Given this list of marker genes Tubgcp5, Szt2, Hps4, Tnrc18 (NCBI Gene Id 381742), Snord42b, Stag1, Nes, Ppih (peptidyl prolyl isomerase H), Hyi, Fbxw4, Zfp592, Rab30, Coq4, Cfap298, Sox1, Peli1, Nf1, Acaa2, Wdr77, Mogs, Krr1, Gm20257, Cops7a, Bloc1s4, Zbtb45, Nckap5, Ift80, Mix23, Pdgfa (platelet derived growth factor, alpha), Tut4, Abcc4, Dgkd, Zbtb7c, Ogfod2, Msmo1, Mir2861 (NCBI Gene Id 100499514), Opcml (NCBI Gene Id 73045), Helq, Phospho1, Psmb1, Sqstm1, Lrrc8b, Zeb1, Gm13427, Gm15927, Spred1, Dhrs1, Cox18, Mapk1, Fscn1, Mapk6, Thoc5, Plekhm3, Gt(ROSA)26Sor, Faim, Brcc3, Mtf1, Tomm5, Nr1h3, Socs5, Bdnf, 1600023N17Rik, BC065397, P4hb, Gdap2, Csrnp2, Psme4, Smad5, Cebpg, Hps5, Tns3, Pym1, Terf1 (telomeric repeat binding factor 1), Mir7648, Proser1, Chkb, Gm42632, Nup35, Plekhh3, Slc38a2, Cyp20a1, Borcs6, Lmo4, Upp2, Kcnq5, Hsd17b4, Mis18bp1, Lrrc8d, Uqcrfs1, 1110020A21Rik, Rab14, Emg1, Vwc2, Pgs1, Adipor1, Mast4, Trp53rka, Rbm38, 2900005J15Rik, Tmem131, Zdhhc7, A430035B10Rik, Bola1, Mttp, Wwtr1, Zfp963, Kctd12, Fdxacb1, Cox4i1, Mad2l1bp, Arl4d, Hivep3, Mir207, Tab2, Zdhhc24, Stat3, Mgat4b, Cyfip1, Lysmd2, Cox7c, Rpf2, Atf2, Gm13783, Gm4925, Gm23639 (predicted gene, 23639), Krcc1, Fance, Zbtb25, Dnal4, Plekha4, Caprin1, Dguok, Nell2, Pex1, Fam98a, Caprin2, Flvcr1, Psma2, Gtf3c3, Traf5, Gm15834, Usp29, Taf11, Map3k7, Wnk1, 4930426I24Rik, Fhl4, Poldip2, Xrra1, Pgbd1, Ptpn21 (protein tyrosine phosphatase, non-receptor type 21), Ube4b, Pfkfb3, Atg2b, Foxk2, Eef1a1 (NCBI Gene Id 13627), Phykpl, Zfp91, Gm23130, Zfp704, 5033417F24Rik, Hnrnpk, Wdr3, Tmem47 (NCBI Gene Id 76833), Fastkd2, Rictor, Golga7, Rccd1, Tpm3, Rnase4, Mir1945, Nop53, Rap1gds1, Polk, Mad2l1, Spr, Rsf1os2, Pik3ca, Fbxo30, Tmem263, Mms22l, Abhd16a, Mark1, Mir99ahg, Sgsh, Faf1, Taf6l, Scrib, Tbce, Mtor, Zeb2os, Dynlrb1, Aff1, Irak4, Adamts20, Fam171b, Tvp23b, Adam15, Tbl3 (transducin (beta)-like 3), Spice1, 4930519P11Rik, Gm5493, Satb2, Cyc1, Alas1, Trappc2, Dtnb, Ppp1r9a, Nol4, Zfp668, Rubcn, Grk4, Ywhae, Arhgap26, Med13, Trmt9b, Gid8, Gm11205, Smc2os, Septin10 (septin 10), Gm13999, Chka, Brpf1, 6530401F13Rik, Mtif2, Gm13620, B4galt2, Abraxas1, Ercc6l2, Pus1, Rps27, Pank1, Trmt6, Rhoc, Gas5, Rfwd3, Slc41a2, Safb2, Id1, Vps52 (VPS52 GARP complex subunit), Mex3c, Nckipsd, St6gal1, Kntc1, Snx30, Tpm1, Bcar3, Dnaja4, Snhg18, Cd164, Srcap, Snrpc, Lnpep, Trmt10a, 2810001G20Rik, Tarbp2, Luzp1, Ptpmt1, Pcbp1, Hscb, Zxdc (NCBI Gene Id 80292), Rab4a, Gba2, Adnp2, Dll1, Tm2d1, Insig1, Arfgap1, Tm9sf1, Hnrnph1, Pcif1, Rhou, Tmem126a, Zcchc14, 4933437G19Rik, Id4, Pmpcb, Slc25a28, Prdm15, Pygo2, Alkbh3, Cd320, Drosha, Ndufb9, Man2c1, Slc22a15, 4930599N23Rik, Lypd1, Gspt1, 3110045C21Rik, Yars2, Mcm3ap, Chmp1a, Ddx6, Itga9, Clcn2, Gas7, Slc37a3, Nol12, Trub2, Dhx8, Akap1, Mospd1, Gtf2a2, Rgl1, Ankrd17 (ankyrin repeat domain 17), Herpud1, Sun2, 1110002L01Rik, Impa1, Fgfr1, Taf10, Gpr137, Polr3b, Abl1, Lrrn3, Plekhg2, Eny2, Ybey, Cetn2, Gm11767 (predicted gene 11767), Gnb2, Sppl3, Mllt11, Slc35a4, Cryzl1, Gm22489, Nsun2, Zfand2a, Golm2, Zfyve16, Bend4, Rabl2, Fus, Apbb1, Sall3, Prima1, Uqcr10, Thg1l, Klhl18, Cpne2, Calm1, Zfp263 (zinc finger protein 263), Gm5577, Kiss1r, Sox6os, H2bc21, Wdr75, Ero1a (NCBI Gene Id 50527), Filip1l, Coq5, Klf13, Tcp1, Rbmx, Dzank1, Med28, Cep104, Dnajc27 (NCBI Gene Id 319948), Sox12, Trp53i11, Nsun6, Hace1 (HECT domain and ankyrin repeat containing, E3 ubiquitin protein ligase 1), Arb2a, Yeats4, Rfx7, Limd2, Plcb4, Ube2z (NCBI Gene Id 319335), Pde6d, Itpk1, Ncdn, Mkks, Kri1 (KRI1 homolog), Dus2, Tapt1, Fxr1, Ppa2, Rragc (NCBI Gene Id 54170), Jpx, Nup188, Tut7, Adgrg6 (adhesion G protein-coupled receptor G6), Spata1, Tet2, Fam227b, Klf6, Mrps18c, Mrps18b, Gm4221, Mtg1, Setd5, Naa60, Smc1a, Pate2, Qser1, 1110025M09Rik, Slc25a17, Gm49405, Cspp1, Slc33a1, Mapk8ip3, L3mbtl3 (L3MBTL3 histone methyl-lysine binding protein), Mettl16, Rragb, Azi2, Csnk2a1, Exoc6b (NCBI Gene Id 75914), Baiap2, Rfxap, Syde2, Fzd8, Ubn1, Cfap68, Afg2a, Pofut2, Ccnb1, Edrf1, Akt3, Brpf3, Arid4b, Atp1b2, Ift57, Myo5a, Bad, Dennd1b, H1f1, Eif4g3, 1700069B07Rik, Naa20, Mrpl39, Ssbp1, St3gal5, Tlk2, Gm17494, Rsrp1, Atxn7l2, Rad51c, Fancm, Epb41l4aos, Ywhaz, Spag4, 4933406P04Rik, Adamts9, Anp32a, Pex11b, Orai1 (ORAI calcium release-activated calcium modulator 1), Hs2st1, Tk1, Malat1, Acvr1, Lamtor4, Mtfr2, Gnaz, Tspan4, Pum3, Eef1akmt2, Carf, Clint1, Tgfbr1, Gm11613, Nudcd1, Alg6, Hspa2 (heat shock protein 2), Wdr20, 4930509H03Rik, Gm15860, Tatdn1, Grik2, Ctsc, A730056A06Rik, Sox6, Rps2, Azin1, Lrrc4b, Rbm3, Intu, Stat5b, Tmem242, Reps2, Naa35, Tial1, Bag2, Rrm2, Pus7l, Mrpl18, Thap12, Alg10b, Arl6ip1, Ube2s, Gtpbp4 (NCBI Gene Id 85330), Med1, Rpl13, Msh2, Hey1, Rnmt, Kiz, Ncapg, Tmem69, Sobp, Ifngr1, Dpysl3, Dennd6b, Prss23, Bivm, 1700086O06Rik, Rap1b, Dmac2l, Ccdc141, Pard3b, Mcm8, Tmem39a, Rsph3a, Gm22357, 2310014F06Rik, Hycc2, Man2c1os, Eefsec, Ccdc107, Mrpl45, Lif, Tmco1 (transmembrane and coiled-coil domains 1), Bmi1, C230096K16Rik, Rnf25, Dolk, Plscr3, Zscan12, Ubxn2a, Tm7sf3, Akirin1, H2ax, Fdxr, Tax1bp3, Slc25a3, Adrb1, Cenpi, Rbm3os (NCBI Gene Id 70226), Mia2, Zic2, Mis18a, Chmp5, Zmat3, Rsbn1l, Eya1, Ncoa7, Edc4 (enhancer of mRNA decapping 4), Mm2pr, Mindy3, Brd4, Hmcn1, Gm17344, Ppcs, Ptpn2, Pin1, Socs2, Uap1, Phf14, Thrap3, 6330562C20Rik, Mtus1, Pdia3, Myl4, Pgap2, Emc8 (ER membrane protein complex subunit 8), Usp31, Wdr12, Rmrp, Parp12, Fbxo45, Calr, BC106179, Ssh2, Mir1904, Gnb1l, Wdr1, Zcwpw2, Odr4, Myc, Rabl3, 2900093K20Rik, E230029C05Rik, Parp1, Cramp1, Poglut2, Pdzd11, Oard1, Mapk7, Rdm1, Nabp2, Spsb3, Ccdc142os, Rims1, Urgcp, Ndufc1, Rpl23a, Hcfc2, Sms, Tpd52l2, Xrcc2, Med17, Myl12a, Gm10501, Gm9828, Rhoj, Cul3, Ehd4, Ubn2, Arid4a, Nacc1, Sp3, Ndfip2 (Nedd4 family interacting protein 2), Cotl1, Gatad1, Dusp4, Rtn4ip1, Shoc2, Mrps12, Tardbp, Cbx4, Kdm4c, Fanca, Pole4, Eaf1, Nudt21, Add3, Polr3f, Cep83, Prmt5 (protein arginine N-methyltransferase 5), Ak4, Shisa6, 4933431K23Rik, Psmg1, Rpl37, Tjp1, Tnks2, Pitpnm2, Bzw2, Nek2, Psme3ip1, Tmem107, Dnaja1, Gm13267, Cdca4, Mtcp1, Rybp, Rpa2 (replication protein A2), Mrpl47, Cep57l1, Pdzrn3, Csnk1a1, Dpp8, Nr2c1, Aftph, Msh6, Smpd2, Babam2, Zfp948, Chek2, Tcf7l2, Atraid, Leng8, Purg, Ilkap, Phldb1, Cpped1, Dlg1, Rnf217, Ice1, Khdrbs1, Zng1, Fpgs, Rft1, Polr1b, Gm26861, Gnptg, 3110056K07Rik, Iqce, Itga4 (NCBI Gene Id 16401), Gm10941, Wdr11, Tnfrsf12a, Grk5, Cnot6l, Dele1, Qrsl1, Wdr18, Larp4b, G2e3, Pdcd2l, Tmem135, Gnas, Arl1, Vps54, Wdr76, Zc3h12c, Mfap1a, Zbtb1, Btf3l4, Rrp9, Srd5a3, Nf2, Mettl6, Ubtf, Lmf2, Spart, Nagk, Rps15, B230217O12Rik, Hmg20a, Wrn, Lfng, Cacng8, Cep63, Rgs7, Pigl, 1110059G10Rik, Rnpepl1, Cbx5, Sfmbt1, Med8, Cops5, Nat8f1, Pnpla3, Rps28, Rnf114 (ring finger protein 114), Angel2, Eapp, Xpnpep3, Fam227a, Etohd2, Sipa1l1, Ywhaq, Rrn3, Atp6v1h, 4930507D05Rik, Zmynd12, Cdk10, 1700020L13Rik, Ncoa2, Txndc12, Cpsf2, Slc20a2, Sbf2, Epm2aip1 (NCBI Gene Id 77781), Crlf3, Lrrc41, Dcaf17, Foxp2, Midn (NCBI Gene Id 70193), Arc, Fbxw8, Smg8, Exosc2, Arhgef11, Nbeal1, Rnf145, Banf1, Manf (NCBI Gene Id 74840), Klf4, Sertad1, Vps53, Gm57488, Gm20517, Etv5, Rbm4b, Etfdh, Eif3j1, Thap2, Usp53, Cep83os, Vav3, Tmx3, Ift140, Hotairm1, Polh, Rdh10, Crot, Piga, Herc1, Fbxo22, Sptan1, Gm19391, Psen1, Zfp219, Rapgef3, Runx2, H3c10, Map3k5, Cox10, Hmox1, Prkce, Snord68, Klf7, 9530051G07Rik, Zkscan2, Gtf3c5, Snx5, Catsper2, Clcc1, Gm12915, Egln3, D030047H15Rik, Rhot1, Mipepos, Lpin2, A330009N23Rik, Abitram, Mir148a, Smim19, Stk17b (serine/threonine kinase 17b (apoptosis-inducing)), Zfp101, Tpp2, Hspa8, Gm2479, Usp19 (ubiquitin specific peptidase 19), Srrd, Snora64, Rhbdd2, Ints9, Hoxa1, Gm25878, Psmg3, Bud23, Ext2 (NCBI Gene Id 99128), Msn, Gm10382, 5930411N13Rik, Diaph3, Rtkn, Asrgl1, Tmbim4 (transmembrane BAX inhibitor motif containing 4), Tafa5, E2f1, Galnt18, Ptk2, 2210016L21Rik, Zeb2, Rgp1, Dpp9, Cerkl, Csf1, Gm16576, Ep300, Pabpc1, Arl2bp, Rbbp8, Zdhhc5, Adamts3, Eya2, 2310057M21Rik, 5730420D15Rik, Nr6a1, Ankrd42, Hmbox1, Prkdc, Slc35e2, Kif9, Pabpc4, Gm7008, Aurkaip1, Pxk, Dnajc17, Gas1, Vps13b, Nt5c3, Cipc, Strn4, Bpgm, Xbp1, Slc30a7, Gm27021, Ndufaf4, Mrpl15, Slc5a6, Ctnnb1, Zrsr2, Prelid3b, Eif1ad, 4930417H01Rik, Dicer1, Mrpl1, Kcnk5, Tex14 (testis expressed gene 14 intercellular bridge forming factor), Wdpcp, Setd3, Ssbp2, Pdgfc, Pola1, 4930432B10Rik, Zfp740, Sertad2, Zeb1os1, Hgs, Morf4l2, Tcea1, Pou2f1, Gm15952, Bag4, Zfp276, Sass6, Ang, Dusp7, Stt3b, Lats2, Polr2l, Fam162a, Cdc27, Pnrc1, Rmi1, Ranbp2, Snip1, Iftap, Asb3, Cop1, Tmem222, Snhg9, Bcl11b, Ppdpf (NCBI Gene Id 73215), Peak1 (NCBI Gene Id 68761), 6330403L08Rik, Eps15l1, Slc9a1, Cbll1, Shc4, Akr1a1, 1700028E10Rik (NCBI Gene Id 69463), Ing1 (inhibitor of growth family, member 1), Zfp672, Mir6392, Itga1, Gm13483, Terf2, Lrrfip2, Sec61a2, Pantr2, Kcnc1, Med20, Ap4m1, Kansl2, Bicd1, Rbx1, Gm5914, Alg14, Ufsp1, Lmln, Mir1938, Trmt44, St13, Oxsm, Styxl1, Cops7b, Gm5106, Ids, Baz2b (bromodomain adjacent to zinc finger domain, 2B), Zbtb37, Cant1, Nsg1, Asxl2, Timmdc1, Cenpv, Pik3r3, Skp1, Kptn, Tnpo1, Dyrk1a, Arhgap11a, Ube2d-ps, Psmd11, Cdca5, Marchf7, Sgpl1, Ccnt1, Zfp771, Setx, Orc1, Gm40190, Jup, Sorcs2, Ptpn4, Mvk, Mad1l1, Hipk2, Dazap1, Anapc1, Pbld2, Mmadhc, Rpl36a, Ndufa7, Cnp, Tomm6, Agk, Oip5, Mrpl58 (NCBI Gene Id 68572), Zmat5, Gm10840, Gm17501, Car8, Ppp1r15a, Znfx1, Slc25a51, Tug1, Arl6, Brip1, Ranbp9, Pik3r4, Dhodh, Mier2, C230035I16Rik, Huwe1, 2010315B03Rik, Dgki, Dcun1d1, Adprs, Trappc1, Polr1d, Mbd2, Cep57, Ogfod1, Zfp444, Mex3b, Gng5, Npc2, Slc26a11, Eef2k, Ankle2, Gpr85, Trmt2a, Zfas1, Lman1, Rad52, Nprl3, Srp14, Crtc3, Gabbr1, Zfyve19, Gm12676, Pkd2l2, Rfc1, Nphp3, Dgat2, Cnep1r1, Nup93, Rab5c, Tmem161a, Myh10, Rab5if, Shroom2, Dcaf8, 1700001G11Rik, H2bc26, Ndufs6, 1110038B12Rik, Irs2, Uba6, Rexo4, Fancc, Gm29417, Zkscan17, 4930500F10Rik, Celsr2, Adcy9, Zfp652os, Scap, Mxi1, Atl1, Phlda1, Phrf1, Tpbg, Lpgat1, Mrpl22, Tbcc, Asap2, Brd2, Cuedc1 (CUE domain containing 1), Lrrc58, Fen1, Slc30a9, Rock2, Aar2 (NCBI Gene Id 68295), Psma6, Ebag9, Serinc1, Il17d, Ppp1r12c, Abcc1, Nova1, Taco1os, Pitrm1, Snhg12, Zfp868, Gtf2h1, Emc6, Thada, Wbp11, Actb, Rgs2, Ddx3x, Wdr74, Mir7075, Atp6v0a2, Eed, Mydgf, Snhg8 (small nucleolar RNA host gene 8), Gm26608, Stil, Glyr1, Sirt3, Nudt6, Ramac, Lancl1, Vhl, Zfp451, Rbm15, Prkar1b, Kpnb1, Hyal3 (NCBI Gene Id 235600), Bcl7a, Anapc10, Flot1, Commd3, Gm36527, Tax1bp1, BC006965, Tor1b, Atg16l2, Foxp1, Ccdc157, 4933408J17Rik, Mpnd, Tmem94, Phtf1, Calcrl, 4930570G19Rik, Rbm34, Kif1b, Cyth2, Cdk9, Prdx1, Ralgapa2, Rpl41, Gm15541, Mrps22, 0610009L18Rik, Uspl1, Arl14ep, Hmgb1, Gpi1, D730045B01Rik, Elac2, Gm11520, Rnf123, Hmgcr, Cic, Reno1, Afmid, 4933431K14Rik, Zfp157, BC005537, Bbip1, Lmtk2, Stard3nl, Snora16a, Riox2, Lsm14b, Atp6v0c, Mapk8, Rasl11b, Ncaph2, Nfyb, Mir8104, Gtf2a1, A130014A01Rik, Gm13594, Usp27x, Set, Actn3, Mlec, Prdm10, Cpne1, Kmt2c, Dnajc19, Fam13c, Zc3h4, Sidt2, Nkrf, Get4 (NCBI Gene Id 67604), Syncrip, Rnf141, Ier5l, 4930540M05Rik, Rps5, Mef2a, Pitpna, Gm7467, Galk1, Gucd1, Usp42 (ubiquitin specific peptidase 42), Dido1, Hmgn2, Stam2, Gm22589 (predicted gene, 22589), Eif4a3, Rps6ka5, Cdca2, Zmym4, Bloc1s6os, Nudt1, Trim35, Srsf7, Itgav, Atp6ap1, Fndc4, Degs1, Dnm2, Zfp850, Fam181b, 3110031N09Rik, Gpc4, Bora, Tmbim1 (NCBI Gene Id 98587), Sra1, Hsd17b7, Stk36 (serine/threonine kinase 36, NCBI Gene Id 73581), Ifrd1 (NCBI Gene Id 15982), Med13l, Stard13, Vmn1r4, Mmab, Gfus, Rab11fip3 (NCBI Gene Id 353068), Gm20544, Atp5pd, Uqcrh, Kif13a, Nsd3, Fan1, Heatr6, Sowahc, Parp3, Ift74, Tmt1a (thiol methyltransferase 1A1), Srgap1, 4933433G15Rik, Ube3b, Nin, Sde2, Bmpr1a, Inpp5k, Lsm4, Nsun5, Klhl12, Itgb1, LTO1, Oser1, Kctd2, Lrig2, Nr2f1, Vps9d1, Kctd10, Spata33, Atp5pb, Auts2, A430018G15Rik, Nubp2, Glrx5, Cxxc4 (CXXC finger 4), Zfp638, Zfp143, Usp13, Rtn4, Zfp467, Mdh1b, Gm20033, Slc4a8, Zswim1, Gm16001, Hp1bp3, Dync1i2, Ei24, Cep152, Snrpb2, Atp6v1d, Dolpp1, Snx24, Mcm7, Sepsecs, Scarna17, Abl2, Plekhg1, A230083N12Rik, N4bp3, Gm2093, Kat7, Kdm2b, Adgrl1, Srsf9, 1600020E01Rik, Ubash3b, Spry4 (NCBI Gene Id 328944), Guf1, Gm26756, Snora78, Zfp958, Zbtb18, Gemin7, Cdc42se1, Pkp4, Ccnc, Ccz1, Tpx2, Ccne2, Opa3, Ncor1, Sntg2, Ahdc1, Nr4a2, 2610035F20Rik, Zfp24, Kctd9, Gpn2, Rpl7, Agrp, Taf5, Mir6935, Idi1, Phax (NCBI Gene Id 72695), Frs3, Bloc1s2, 4930589L23Rik, Trmt13, Mrpl2, Glb1l, Fbxw5, E230016M11Rik, Eif4e, Rnf6, Psma1, Frmd4a, Arl4aos, Armh3, Rai14, Wdr53, Pabpn1, Gm25744, Hyls1, 1700122E12Rik, Mbd1, 2900076A07Rik, Trappc4, Topbp1, Hsp90ab1, Coa5 (cytochrome C oxidase assembly factor 5), Hnrnpl, Slx4ip, Ppp1r10, Cbx1, Man1c1, Kbtbd4, Rbm48, Arl6ip6, Ubac1 (ubiquitin associated domain containing 1), Ngly1, Ccdc148, Mrpl53, Pigt, 5430400D12Rik, Cdk14, Rsrc2, Ercc6l, Cyren, Lrrcc1, Gm24067, Cobll1, Unc79, 4933439C10Rik, Pid1, Nufip2, Cplane1, Gm15663, Znrf2, Zscan26, Tedc2, Tent5a, Poc5, Rps18, A130010J15Rik, Fgfr3, Ahcyl1, Pigk, Pde10a, Efr3a, Neurod1, Rplp0 (NCBI Gene Id 64336), Ppp4c, Mir8102, Rnf38, Anapc13, H3f3b, 4930509E16Rik, Herc3 (hect domain and RLD 3), Tle3, Trp53inp2, Extl2, Arl16, Kat2a, Ubc, Srebf1, Tmem260, Dbf4, Nme3, Odad3, Cabin1, Unc50, Arnt, Ube2j1, Zyg11b, Wsb1, Akap9, 4930583K01Rik, Slc25a40, Cinp (cyclin dependent kinase 2 interacting protein), Jarid2, Gm24044, Tubb5, Upf3a, Mir17hg, Whrn, Mylip, Exoc7, Lmnb1, Ndufb5, Rps12, Zswim6 (zinc finger SWIM-type containing 6), Hnrnpf, Kcnd2, Kansl1 (NCBI Gene Id 76719), Sesn1, Denr, S2bpcox16, Gm17057, Jmjd7, Gm24576, Zfta, Tmem106b, Pcgf5, Eif2s1, Ppid, Tex9, Plat, Reps1, Erh, Rtca, Dffb, Mllt10, Creld1 (NCBI Gene Id 171508), Glcci1, Arl6ip4, Mir3069, Rwdd4a, Nedd4, Ssmem1, Nfyc, Comtd1, Ankrd29, Bag1, Septin7, Abcc10, Vcl, 5430405H02Rik, Erlec1 (endoplasmic reticulum lectin 1), Ecd, Fam72a, Chid1, Ptprk, Mcm4, Septin11, Myo6, Rbks, Tubb4b, Slc30a4, Tgfb2, Rnf128, Pxn, Nmd3, Nudt3, Rps10 (NCBI Gene Id 67097), Slc39a9, Cops4, Mir5627, Morc2a, Trappc10, Lsm2, Diaph2, A730035I17Rik, Phb2, Soat1, Chd1, Ears2, Nsrp1, Tmem168, BC049715, Mrpl20, Lsm14a, Tollip, Gm17249, Ankmy2, Gm14379 (predicted gene 14379), Wls (wntless WNT ligand secretion mediator), Klhdc4, Relt, Zfp329, Mgme1, Bltp3a, Cdc37, Usp37, Cdc37l1, Ubfd1, Klf3 (Kruppel-like transcription factor 3 (basic)), Gm4189, Ppil6, Fermt2, Epo, Fbxo7, Mapre2, Fancl, Gm11696, Rcor1, Zfp189, Eif2ak4, Abcg2, Negr1, Stk16, Homer1, Pgrmc2, Sp3os, Sptbn1, Tmem199, Gm16892, Csrnp3, 1700047K16Rik, Ggps1, Slc25a15, Trim2, Ephb4, Cert1, Trim33, Rab13, Dusp1, Ranbp1, Gm1604a, Gm24355, Xylt2, Lasp1, Agtpbp1, Psmd13, Ppp1ca, Snhg16, 2700099C18Rik, Hells, Tent4b, Api5, Polr2a, Slc25a36, Ttpa, Tlcd3a, Snord1c, Vangl2, Rps25, Srd5a1, Ubr5, Ttc14, Sltm, Slc16a14, Stxbp5, Taf4, Ddhd1, Acp2, Mir3960, Taf1d, 1810012K16Rik, Noc2l, Itpr2, Kdsr, Zfpl1, Ash2l, Mknk2, Rps29, Mettl13, Zfp82, Map2k2, Clock, Snu13, Cflar, Cap1, Pde4d, 1700040D17Rik, Paxbp1, Adgra3, Adgrl3, Arid5a, Kdm6a, Aplp2, Park7, Paxip1, Dcps, Bach2, Tprkb, Ube3c, Gna13, Gm29642, Zc3h7a, Gtf2b, Ndufs3, Gm14662, Rpusd4, Phtf1os, Rbm39, Stk38, Gm12841 (predicted gene 12841), Dhrs13, D930048N14Rik, Plod1, C8g, Gm9958, 6030458C11Rik, Nfkbiz (NCBI Gene Id 80859), Btf3, Sfpq, Gm27239, Mtch1 (NCBI Gene Id 98058), Acsl4, Sez6l, Rpl24, Rbm12, Katnal1, Ddx19a, Pdcl, Spg11 (NCBI Gene Id 98786), Zfp382, Adgra2, Ddx39b, Ap3s1, Stk11, Nipbl, Fstl1, Acadm, Rest, Slc38a1, Far1, Ttc39d, Dnajb2, Gm15420, Gm4419, Lsm1, E130311K13Rik, Snrpd3, Cand1, Usp15, Ubxn1, Mir5130, Rps26, Actg1, Pkia, A830082K12Rik, Rcbtb2, Gng2, Atp2a2, Tmtc2, Mir423, Fbxo21, Sorbs2, Lsm3, Snora24, Sdf4, 4930524O07Rik, Farsa, Gm10655, Nuak1, Cggbp1, Fastk, Senp5, Snhg6, Letm1 (leucine zipper-EF-hand containing transmembrane protein 1), Arfgef1, Smc4, 4931406C07Rik, Rb1, BC048644, Arid1a, Tbl1xr1, here is a description of the gene set: Mouse Gene Set: PHF2_TARGET_GENES studied in species Mus musculus Genes containing one or more binding sites for (Phf2) in their promoter regions (TSS -1000,+100 bp) as identified by GTRD version 20.06 ChIP-seq harmonization. from publication Yevshin I, Sharipov R, Kolmykov S, Kondrakhin Y, Kolpakov F (PMID 30445619)